Given this list of marker genes EIF2B2, EIF2B3, EIF2B4, EIF2B5, EIF2AK2, EIF2S1, EIF2B1, here is a description of the gene set: Human Gene Set: KEGG_MEDICUS_REFERENCE_PKR_EIF2ALPHA_SIGNALING_PATHWAY studied in species Homo sapiens PKR-eIF2alpha signaling pathway. Pathway ID: N00571. Pathway type: Reference. Pathway class: nt06170 Influenza A virus (IAV). Pathway Definition from KEGG: EIF2AK2 -> EIF2S1 -| EIF2B